Given this list of marker genes AGTPBP1, SCN1B, DHX30, CPPED1, SHMT1, ID2, CTNS, SPOUT1, PLXNA1 (NCBI Gene Id 84202), BORCS8-MEF2B, RAP1GAP, EVPL, CYP2E1, DHRS3, SNCG, OSBPL3, ACADL, ZMYM1, B9D1, SLC12A4 (NCBI Gene Id 6560), ASB5 (ankyrin repeat and SOCS box containing 5), COL5A3, B4GALT1, ECRG4, LIN37 (NCBI Gene Id 55957), VNN1, TSC1, PALS2, EPHA1, SIPA1, CUX1, UROS, MYO15A, here is a description of the gene set: Breast cancer expression clusters. Human Gene Set: MODULE_366 species: Homo sapiens